The following is a description of a gene set: Mouse Gene Set: GOBP_L_AMINO_ACID_CATABOLIC_PROCESS studied in species Mus musculus The chemical reactions and pathways resulting in the breakdown of an L-amino acid., and this is the list of marker genes: Glud1, Sds, Hdc, Kmo, Shmt1, Auh, Nos3, Aldh8a1, Il4i1, Afmid, Cbs, Nos2, Gls2, Atp2b4, Ftcd, Arg1, Nos1 (NCBI Gene Id 76730), Oat, Prodh, Prodh2 (proline dehydrogenase (oxidase) 2), Ddah1, Ahcyl, Gpt, Hal, Got2, Gls, Ppat, Dlst, Bckdk, Sdsl, Dao, Kyat1, Pipox, Ido1, Agxt2, Hpd, Csad, Acmsd, Ivd (NCBI Gene Id 98988), Ido2, Hgd, Tdo2, Mccc2, Hmgcll1, Mat1a, Gad1, Aldh4a1, Hmgcl, Kynu, Tha1, Gpt2, Qdpr, Pah, Adhfe1, Cdo1, Gcat (glycine C-acetyltransferase (2-amino-3-ketobutyrate-coenzyme A ligase)), Asrgl1 (NCBI Gene Id 66514), Fah, Got1, Gad2, Aadat, Amdhd1, Arg2, Mccc1, Tat, Ahcy, Aass, Haao, Tdh, Uroc1, Ddo, Agxt, Kyat3, Gstz1